The following is a description of a gene set: studied in species Homo sapiens Depressed nasal bridge Human Gene Set: HP_DEPRESSED_NASAL_BRIDGE Posterior positioning of the nasal root in relation to the overall facial profile for age., and this is the list of marker genes: RPS20, SCARF2, DEAF1, SNX14, MAP3K7, KAT8, RPS17 (NCBI Gene Id 6218), UHRF1, MTX2, PAM16, EDA, ELN, HSD17B4, RAB3GAP1, SLC3A1, HES7, POGZ, PEX26, PEX5, RPS23, NRAS, TCF20, MKS1, HDAC4, CEP19, RPS26, PIGG, CREBBP, PEX14, POLR3A, KIF11, TOE1, HECW2, KCNH1, CSPP1, ACOX1, TAC3, GLB1, HESX1, SUPT16H, USP9X (NCBI Gene Id 8239), CEP290, MADD, EEF1A2, ETFB, CNOT1 (CCR4-NOT transcription complex subunit 1), BBS9, LAMA5, COL9A3, NFIX, DHX30, FTSJ1, LINS1, KAT6B, AGA, NSUN2, UBE2A, NAGA, PPP1R13L, FBXO28, WASHC5, RPS7, SRD5A3, BBS5, TSR2, MAB21L1, BRAF, IL11RA, PEX12, LARP7, UGP2, CASK, FLNB, NRCAM, EIF2AK3, NMNAT1, ASH1L, RPS19, OBSL1, PGM2L1, DPYD, SPRY4, SCN1B, GJA5, CDCA7, CTCF, ETFA, CHD7, IQSEC2, FRAS1, COL1A2, PREPL, FREM1, ABCC9, CCDC22, ROR2, NHLH2, RAF1, TP63, KIAA0586, AUTS2, BBIP1, AMMECR1, MGP, KDM6A, IFT56, SOX9, TTC8, MAP2K2, BLTP1, PDE4D, SUFU, SLC5A5, IL6ST, RALGAPA1, POR, ERF, MYMK, SLC45A1, ATRX, POU1F1, NF1, GPC6, PRMT7, MAP2K1, PURA, MRPS14, HELLS, IFT52, PIK3C2A, CUL4B, GNAO1, DNMT3B, DVL3, PRKD1, SPEN, BBS4, KISS1, GPC3, KCTD1, ADAMTS3, LUZP1, PRDM16, DYNC2H1, TRIM32, H4C9, KREMEN1, FH, GLI3, RPS29, GNPAT, GAD1, RPL27, NSD2, RPL15, ADAMTSL2, SLC32A1, ADGRG6, LTBP3, RAI1, GTPBP2, RPL18, EZH2, LHX4, DYNC2I2 (dynein 2 intermediate chain 2), ANK1 (ankyrin 1), STAG2, TFE3, TRIP11, FGFR2, KIF21A, DYNC2I1, TMEM216, CAMKMT, MEGF8, ANTXR1, PIGT, WDR35, IPO8, CFAP418, SHH, MAN2B1, RNU4-2, QARS1, COL2A1, SMAD2, SMARCC2, PEX6, PIK3R2, RSPRY1, RPL35, RPL8, IFT80, HOXB1, COL11A2, UBE4B, SLC1A4, EXOSC1 (NCBI Gene Id 51013), PIGN, ASCC3, PAX3, SYNE1, ZBTB18, GNRH1, CSGALNACT1, SOST, PEPD, DUOX2, DYNC2LI1, BMP4, FAR1, FGF8, KCNA1 (potassium voltage-gated channel subfamily A member 1), HUWE1, YARS1, ADNP, RERE, WDR11, NPR2, SOX4, COL18A1, TRIP12, SLC18A3, GNS, GPC4, FBN1, AFG2A, TBX2, ARX (NCBI Gene Id 619216), GLUL, POLRMT, PAX1, GATA1, GNRHR, IFT81, SKIC2, PEX3, NSRP1, RNF2, PNKP, CHD8, IFT172, RAB3GAP2, UBE3B, RPL9, STX16, DIS3L2 (NCBI Gene Id 282696), IARS2, SMARCB1, ADA2 (adenosine deaminase 2), ACBD6, LRP2, ARID1B, PEX2, ZBTB24, PPM1B (NCBI Gene Id 8652), RAPSN, HSPG2, TWIST2, POLA1, SCN2A, CDH11, DNA2, TAF1, CRLF1, PRIM1, PRKCZ, PIGU, MTOR, TAF6, DPF2, GJA8, PEX11B, CDKN1C, MED12L, SPECC1L, SIN3A, AHDC1, TAOK1, PIGP, DHCR7, GATAD2B, SMARCA4, PLCB3, CDC42BPB, TBX4, ARID2, PLOD1, PIK3CA, RUNX2, GBA1, EBP, RPS10, MED13L, ADAMTS2, PEX16, DMXL2, PDPN, MAF, ANKH, BBS7, RIPK4, SLC6A9, RAD21, COL1A1, PRPS1, SMARCE1, TFAP2B (transcription factor AP-2 beta), POLG2, DPH2, VARS1, NSMF, DDB1, TRPM3, ALX4 (NCBI Gene Id 64068), NEPRO, CCNQ, WBP4, RPS28, SOS1, SMO (NCBI Gene Id 6608), RAB23, PEX19, DLL3, CBL, MARS2, MAGEL2, CCBE1, BMPR1A, AXIN1, MYOD1, FOXG1, RYR3, ADAMTS10, MINPP1, TRPV6, SMPD4, PIGA, ZBTB20, MACF1, EPG5, POLR1A, SMG9, AFG2B, ZIC2, NAA10, DHCR24, IFT140, NSDHL, CASZ1, FILIP1, CHST3, ARL3, GRIN1, TPO, GRM7, TMEM147, PEX7, RPS6KA3, GLI2, KCNAB2, SDCCAG8, BBS12, XYLT1, FLNA, FGFR3, POLE, GMNN, MIPEP, SP7, PTH1R, SMC1A, ALDH6A1, RPS27, AKT3, GNB2, SLC26A2, RPS24, GOLGA2, RMRP, EXTL3, MRAS, BBS2, PEX13, GPX4, CACNA1C, FLII, SETBP1, KCNE5, H3-3A, LONP1, EED, CRIPT, VANGL2 (NCBI Gene Id 57216), HBB, B3GALT6, PITX1, GNAS, FAT4, H4C11, BBS1, DVL1 (dishevelled segment polarity protein 1), MUSK, RPL31, JARID2, EDARADD, WDR4, HDAC8 (NCBI Gene Id 7492), TRRAP, RTL1, HNRNPR, KAT5, GLIS3, MESP2, TUBB, NSD1, TRIO, MMP23B, PIK3CD, SMC3, B3GAT3, ACSL4, MYH3, SIM1, CUL7, TONSL, DDR2, VPS35L, SPOP (NCBI Gene Id 8405), SLC25A22, LIG4, EDAR, DPYSL5, CANT1, BMPER, RIPPLY2, EYA1, WNT5A, MTHFR, PROK2, IFT27, PAICS, KIF7, SIK1, PROKR2, MN1, SCLT1, THSD1, CLIC2, EFEMP2, PRKAR1A, MLXIPL, DICER1 (dicer 1, ribonuclease III), WAC, KYNU, LHX3, TG, SON, PSAT1, GABRD (gamma-aminobutyric acid type A receptor subunit delta), AKT1, NEK1, SEPTIN9, MECP2, TSHB, BBS10, PROP1, IFT74, LFNG, MKKS, TRIM8, ARSL, RHOBTB2, PIGQ, SOX11, FAM20C, RPL11, TRIM37 (NCBI Gene Id 4591), PDGFRB, ALG9, BRD4, CDH2, SHROOM4, SLC35C1, ADAT3, U2AF2, IYD, INTU, ARL6, ALG3, PMM2, NEXMIF, FREM2, FZD2, IDUA, DOCK6, TBCE, USB1, DOK7, RPS15A, SMARCAL1, KMT2D, SLC39A13, NIPBL, HYAL1, B3GLCT, ZMPSTE24, EP300, UQCC2, DUSP6, ARSB, NBN, TUBA1A, TMEM107, CCND2, KRAS, ASXL1, LZTR1, DUOXA2, HEPACAM, ZNF292, MEF2C, PCLO (NCBI Gene Id 56630), ACAN, FOXC1, TALDO1, MAPRE2, FOCAD, CTU2, SIX2, GRIP1, ETFDH, SETD5, LBR, PGAP1, MEG3, RECQL4, KLHL7, CD96, COL11A1, SHOX, ZSWIM6, BICRA, DPH1, TGIF1, CRELD1, PIGL, FGF17, AGL, NANS, NXN, KIAA0753, BUB1B, KNSTRN, MED27, SMOC1, SNAP29, PIGY, CDK10, TACR3 (tachykinin receptor 3), FDFT1, ZFX, PEX1, HS6ST1, TMEM94, HEATR3, TFAP2A, SCO2, SCYL2, FOXL2, HRAS, P4HTM, PTEN, DPM1 (dolichyl-phosphate mannosyltransferase subunit 1, catalytic), GJA1, PAK2, MED12, MDH1, SUMF1, CEP57, WDPCP, FUCA1, NPHP1, LZTFL1, SEMA3E, DLK1, KDM6B, SOX5, COG8, RPL5, BMP2, AIFM1, ASXL3, KISS1R, INPPL1, PEX10, RPL26, SLC25A24, PLXNA1, NSMCE3, ARID1A, PITX2, GNPTAB, CDKL5, TCF3, NEUROD2, RAP1B, MYCN, JAG1, METTL23, SCAPER (NCBI Gene Id 92909), SKI, WDR26, NUP88, RPL35A, TWIST1, SH3PXD2B, CCN2, SMARCD1, FGFR1, PRKAR1B, TRPV4